Given this list of marker genes Rdh13, Cyp2j9, Rest, Cyp1b1, Acox1, Ces2c, Cyp2b9, Cyp4a31, Pla2g2f, Elovl2, Dhrs7, Cyp2a5, Rbp1, Alox8, Akr1c20, Aldh8a1, Sphk1, Gstp-ps, Dkkl1, Cyp1a2, Star, Cyp2b10, Cyp2j7, Akr1c14 (aldo-keto reductase family 1, member C14), Rdh16f2, Afp, Rdh1, Grin1, Ptgis, Akr1c19, Awat2, Hsd17b1, Cyp2d9, Cyp2a4, Pnpla2, Ces2a, Cyp2d12, Cyp4f14, Cyp11b1, Cyp4a12a, Lrat, Abcd2, Plb1, Adh7, Cyp2g1, Cyp4f40, Ptgs1, Cyp2b13, Abcd1, Gpx4, Hsd11b2, Cyp4a12b, Ahr, Cacna1h, Kcnma1, Adh4, Gstp1, Akr1c6, Cyp2a12, Cyp17a1, Rpe65, Adh6b, Dhrs4, Clcn2, Prkg1, Cyp2c55, Inhba, Alox12, Dgat1, Cyp2j5, Dgkq, Mgll, Bmp6, H6pd, Ednrb, Bco2, Ces1f, Bmp2, Rdh5, Gstm7, Ces2e, Cyp4a10, Cyp2b19, Cyp2d22, Aldh1a1, Srd5a2, Cyp4a32 (NCBI Gene Id 674313), Ephx2, Rdh14, Cyp4a14, Cyp2c50, Bco1, Cyp2c29, Bmp5, Rdh11, Scnn1b (NCBI Gene Id 20277), Cyp2c37, Mgst3, Rdh12, Cyp46a1, Dhrs9, Alox5, Gstp2, Ggcx, Ces1e, Adh6a, Dagla, Stard3, Creb1, Cyp2c38, Cyp1a1, Cyp4a30b, Acsl4, Elovl5, Cmtm2a, Cyp2j6, Daglb, Hsd17b3, Bglap, Ptgs2, Rdh9, Pla2g4a, Rdh8, Rbp4, Dkk3, Cyp4f13, Cyp2b23, Adh1, Hsd17b6, Scp2, Cthrc1, Cyp11b2, Cyp4f15, Cyp2a22, Tmem135, Cyp2u1, Hsd3b4, Gstp3, Cyp2d10, Alox15, Hsd17b4, Ptges3, Rdh16, Acot8, Ptges, Dab2, Akr1c13, Dgat2, Acsl1, Sco1, Stat5b, Cyp4a29, Pnpla8, Akr1c18, Cyp2t4, Pnlip, Fads1, Rdh7, Cyp2j12, Hsd3b8, Wnt4, Cyp2d34, Ppargc1a, Cyp21a1, Cyp2s1 (cytochrome P450, family 2, subfamily s, polypeptide 1), Akr1cl, Ehhadh, Lipe, Sdr16c5, Sdr9c7, Cyp2e1, Cyp11a1, Gpx1, Alox12b, Rdh10, Aloxe3, Rdh19, Aldh1a3, Fads2, Cyp2f2, Dhrs3 (dehydrogenase/reductase 3), Hsd3b5, Aldh1a2, Egr1, Acaa1a, Akr1c12, Abca4, Cyp2j11, Cyp2c39, Cyp19a1, Ephx1, Akr1b1, Srd5a1, Hsd3b9, Retsat, Ptgr1, Cyp2c54, Cyp2j13, Ptgds, Cyp4f18, Cyp2d26, Akr1c21, Cyp2d11, Acaa1b, Cyp2c23, Ptges2, Cyp2j8, Alox12e, Cyp2c40, Bglap2, Gprc6a, Ces1d, here is a description of the gene set: studied in species Mus musculus The chemical reactions and pathways involving an olefinic compound, any compound which contains a carbon-carbon double bond (aka C=C). Mouse Gene Set: GOBP_OLEFINIC_COMPOUND_METABOLIC_PROCESS